The following is a description of a gene set: This event has been computationally inferred from an event that has been demonstrated in another species.<p>The inference is based on the homology mapping from PANTHER. Briefly, reactions for which all involved PhysicalEntities (in input, output and catalyst) have a mapped orthologue/paralogue (for complexes at least 75% of components must have a mapping) are inferred to the other species. species: Mus musculus Reactome Pathway: Activated NTRK2 signals through FRS2 and FRS3 part of: Signaling by NTRK2 (TRKB) electronically inferred by orthology from the curated human pathway, and this is the list of marker genes: Ntf5, Frs2, Bdnf, Grb2